The following is a description of a gene set: Human Gene Set: GOCC_CONNEXIN_COMPLEX studied in species Homo sapiens An assembly of six molecules of connexin, made in the Golgi apparatus and subsequently transported to the plasma membrane, where docking of two connexons on apposed plasma membranes across the extracellular space forms a gap junction., and this is the list of marker genes: GJA10, GJC3, GJA1, GJC2, GJA8, GJC1, GJB2 (NCBI Gene Id 2706), GJB1, GJA9, GJD2, GJA3, GJB4, GJE1, GJA4, GJD3, GJD4, GJB5, GJB7, GJA5, GJB3, GJB6